The following is a description of a gene set: from publication Schaeffer EM, Marchionni L, Huang Z, Simons B, Blackman A, Yu W, Parmigiani G, Berman DM (PMID 18794802) species: Mus musculus Mouse Gene Set: SCHAEFFER_PROSTATE_DEVELOPMENT_48HR_UP Genes up-regulated in the urogenital sinus (UGS) of day E16 females exposed to the androgen dihydrotestosterone for 48 h. Cancer cells differentiate along specific lineages that largely determine their clinical and biologic behavior. Distinct cancer phenotypes from different cells and organs likely result from unique gene expression repertoires established in the embryo and maintained after malignant transformation. We used comprehensive gene expression analysis to examine this concept in the prostate, an organ with a tractable developmental program and a high propensity for cancer. We focused on gene expression in the murine prostate rudiment at three time points during the first 48 h of exposure to androgen, which initiates proliferation and invasion of prostate epithelial buds into surrounding urogenital sinus mesenchyme. Here, we show that androgen exposure regulates genes previously implicated in prostate carcinogenesis comprising pathways for the phosphatase and tensin homolog (PTEN), fibroblast growth factor (FGF)/mitogen-activated protein kinase (MAPK), and Wnt signaling along with cellular programs regulating such 'hallmarks' of cancer as angiogenesis, apoptosis, migration and proliferation. We found statistically significant evidence for novel androgen-induced gene regulation events that establish and/or maintain prostate cell fate. These include modulation of gene expression through microRNAs, expression of specific transcription factors, and regulation of their predicted targets. By querying public gene expression databases from other tissues, we found that rather than generally characterizing androgen exposure or epithelial budding, the early prostate development program more closely resembles the program for human prostate cancer. Most importantly, early androgen-regulated genes and functional themes associated with prostate development were highly enriched in contrasts between increasingly lethal forms of prostate cancer, confirming a 'reactivation' of embryonic pathways for proliferation and invasion in prostate cancer progression. Among the genes with the most significant links to the development and cancer, we highlight coordinate induction of the transcription factor Sox9 and suppression of the proapoptotic phospholipid-binding protein Annexin A1 that link early prostate development to early prostate carcinogenesis. These results credential early prostate development as a reliable and valid model system for the investigation of genes and pathways that drive prostate cancer., and this is the list of marker genes: Wif1, Mpi, Fdx1, Calb1, Zbtb8b (NCBI Gene Id 215627), Nampt, Plet1, Fam110c, Ssr3, Serinc3, 1700001L05Rik, Nqo1, Aoc1, Suox, Mmp7, 4930523C07Rik, Cd24a, 1110059E24Rik, 5033430I15Rik, Emb, Ctso, Vps37b, Adgrg2, Selenof, Cebpd, Kcnd2, Cyp26a1, Agr2, H2-T11-ps, Tpd52l1, AI661453, Arhgef5, Acsm3, Glul, Acaa2, Tmem40, Sp5, Pias1, Kcnj16, Afm, Errfi1, Ptgr1, Pkp3, Col9a3, Cobll1, Cdh1, Dynlt1b, Coro2a, Gspt2, Abca5, St3gal1, Phyhd1, Rdh10 (retinol dehydrogenase 10 (all-trans)), Ccbe1, Cxcr4, Fam3c, Mfsd2a, Ptpn13, Anxa1, Tmc4, Sipa1l1, Foxa1, Sertad4, Kcnk1 (potassium channel, subfamily K, member 1), Fxyd4, Arhgap20, Krt19, H2-Q2, Efemp1, Bcl2l1, Lratd2, Apol7a (apolipoprotein L 7a), Atp2c2, Adarb2, Map3k21, Tsen15, Aldh1a3, Cyp1b1, Slc25a30, Ankrd1, Abhd12, Il13ra2, Tenm1, Pdgfc, Gas6, Lrrc26, Crybg1, Gdpd2, Ripply3, Nrip1, Hpgd, Shh, Eaf2 (NCBI Gene Id 106389), Kcnmb4, Ephx2, Rab11a, Tmprss2, 9530068E07Rik, Krt7, Hoxb13, Chp1, Tspan13, Wnt4, Masp1, Lrrk1, Pls3, Lancl3, Edaradd, Upk2, Mien1, Aldh1a1, 2810032G03Rik, Lypd2, Ano1 (NCBI Gene Id 233978), Bend4, Sar1b, Bdh1, Susd3, Tst, Igsf5, Vldlr, Tinagl1, Wnt9b, Emc4, Myof, Clic6, Edn1, Gpr155, Kctd12b, Ccdc198, Pla1a, Mdfi, Rab17, Nalf1, Krt78 (NCBI Gene Id 70279), Bspry (B-box and SPRY domain containing), Usp6nl, Tesc, Elf3 (E74-like factor 3), Arc (activity regulated cytoskeletal-associated protein), Map3k5, Otulinl, Dner (delta/notch-like EGF repeat containing), Pcdh9, Dusp6, Ly6g6e, Kcnn4, Smoc1, Hhip, Mpp7, Ergic1, Fam162b, Bcl2, Pllp, B3gnt8, Gclc, Rab3ip, Gpx2, Cdh16, Tmem51, Pla2g4a, Cfap20dc, Nkpd1, Macir, Alox12, Col24a1, Cys1, Rprm, Dhrs3 (dehydrogenase/reductase 3), Skap2, Synpr, Aldh1a2, Ly6a, Pantr1, Tmc7, Tmem184a, Bbs9, Plscr1, Atp1a1, Spink8, Col4a5, Il33, N6amt1, Manba, Adamts16, Tcim, Sall3, Colgalt2, Anxa3, Ripor3, Gdpd1, Gm21292, Insl6, Ttc6, Aldh6a1, Hkdc1, Sdhaf2, Pid1, Tiparp, Sprr1a, Kdm5d, Erp29, Pnpt1, Sptssa, Gsdmc, Sorbs2, Hopx, Rasd1, Rcsd1, Mroh4, Card19, Camk4, Nxf1, Epha3, Cldn4, Cyp7b1, Calcrl, Ecm1, 2700046A07Rik, Erp44, H2-T23, Rnf32, Ubqln2, Entrep2, Mkx, Abcc4, Gabarapl2, Tacstd2, Rab25, Slc36a2, Usp2, Aldh3b2, Ddx3y, Sct (secretin), Krt13, Gsta3 (glutathione S-transferase, alpha 3), Maf, Sult5a1, Fgf12 (NCBI Gene Id 320320, fibroblast growth factor 12), Ddit4l, Wnk2, Mboat1, Mt2 (metallothionein 2), Arhgef26, Gsn, Tmem35b, Aif1l, Ptges, Leprotl1, Tmed6, Trmt9b, H2-D1, Tmem9b, Acot1, Pros1, Lmo4 (LIM domain only 4), Clu, Zfyve21, Id3, Crot, Slc39a8, Tspan1, Ramp1, Tmem117, Gsta4, D17H6S56E-5, Mbp, Hdac9, Tfcp2l1, Sdr42e1, Esm1, Klf9, Mthfd2, Anxa9, Psca, C630043F03Rik, Bri3, Ralgps2, Nsmce3, Ppfibp2, Dcdc2a, Slc1a5, Itgb4, Asb13, Mafb, Glp2r, Tmtc4, Klf15, Agtr1a, Iscu, Nmrk1, Slc9a2, Gadd45g, Aqp3, Rgs2, Llgl2, Prr15, Trim2, Calm1, AA986860, Fgfr3, Nt5e, Id2 (inhibitor of DNA binding 2), Tfap2c, 4931406C07Rik, Spint1, Sh3yl1, Lypd6, Plxna2, Igfbp2, Endod1, Cyth3, Epcam, Ssty2, Rbbp7, Tapbpl, Meig1 (meiosis expressed gene 1), Grp, Cpm, Tcf15, Gprc5b (NCBI Gene Id 64297, G protein-coupled receptor, family C, group 5, member B), Retreg3, Adgrb1, Smox, Acsl4, Psapl1, Tmem44, Pdgfd, Hsd17b12, Cystm1, Fkbp5, Cbr2, Ceacam1, Trpv4, Loricrin (NCBI Gene Id 99536, loricrin cornified envelope precursor protein), Krt15, Phlda3, Slc16a7, Ggact, Col4a6, Nipal1, Tmem37, Twf2, Slc5a9, Rspo3, Calca, Dennd2d, Ermp1, Cemip, Aff1, Dram2, Tsc22d3, Slc2a12, Adh1, Smagp, Plch2, Snta1 (syntrophin, acidic 1), Hoxd8, Plcd1, Eva1c, Fam83h (NCBI Gene Id 105732), Sp6, Trpv6, Crispld2, Eppin, Rnase4, Myo3b, Dcxr, Leprot, Nrn1 (neuritin 1), Adamtsl2, Emp2, Eif2s3y, Batf3, Lyrm4, Bhlha15, Fut9, Adgrg1, Lynx1, Ahcyl2, Acss1 (acyl-CoA synthetase short-chain family member 1), Elovl2, Gata3, Ptn, Nck2, Slc31a2, Clca1, Tuft1, Lamp2, Napsa, Plscr2, Bdh2, Capn5, Rasl11b, Krt23, Dusp14, Dmrtc1a, Gng12, Gpld1, Rab15, Tbpl1, Slco4c1, Rnf128, Tle6, Glb1l2, Adamdec1, Itm2b, Xpr1, Sema3b, Prom2, Or2ak6, Sfrp2, 2810001G20Rik (NCBI Gene Id 66456), Hebp2, H2-Q5, Cdh8, Nkx3-1, Mrps6, Id1, Stat5a, Sgk1, S100a14, Fam149a, Pts, Nudt7, Sult1a1, Gstt3, Cyp2f2, Vamp8, Pcolce2, Lmcd1, Rab5c, M6pr, Cited2, Sox9, Slco2a1, Cspg5, Micall1, Aspn, Trhr, Dlg3, Col6a4, Pdlim2, Ly6e, Scnn1a, Atp8a2, Arhgef16, Dio3, Irs4, Spink5, Plac8, Tspan12, Pigf, Mapk13, Fgfr2, Car14, Cldn23, Hmgn3, Ackr3, Sec11c, Nfkbia, Lpar6, Penk, Fxyd3, Slitrk6, Sult1e1, Dnase1l2, Manf, Wnt6